The following is a description of a gene set: studied in species Homo sapiens from publication Chen Y, Wang X (PMID 31504780) Human Gene Set: MIR4729 Genes predicted to be targets of miRBase v22 microRNA hsa-miR-4729 in miRDB v6.0 with MirTarget v4 prediction scores > 80 (high confidence targets)., and this is the list of marker genes: PDCD6IP, OGFRL1, CEP350, CHFR, STARD13, TBC1D12, CBFA2T2, DCAF10, ADAMTS5, CALHM5, ZBTB43, RFX3 (regulatory factor X3), CCNYL1, PLAC8, DNAJC9, KLF5, EIF1AY, ADD3 (NCBI Gene Id 121), DDT, MARCKSL1, EEA1, RORA, PLCXD3, NCAPD2, GRAMD2A (GRAM domain containing 2A), CHP1, GRM8, PAXIP1, HTR7, NECTIN1, GINS3, AGTPBP1, SREK1IP1, ACVR2A, DGKH, FGFR1OP2, TBCA (tubulin folding cofactor A), KLHL1, NT5M, CEP76, FUT2, IRS1, STEAP2, ZC4H2, SLC9A2, PAIP1, KIF21A, FGA, RBFOX1, PRR12, RARS2, INIP, SEC14L1, SGIP1 (SH3GL interacting endocytic adaptor 1), STX11, BRWD3, IL22, GABRA1, POU2F1, UBE2N, EXOC5, ITGA4, ACIN1, CDH9, HTR2C, SANBR, C5orf15, PDLIM5, JAZF1, TLR3, PTP4A1, PTPMT1, OLFM4, MDM2, CREBZF, TBX5, ALKAL2, UBE2QL1 (NCBI Gene Id 134111), RIN2, TMED10, CELF4, ATP8A1, LPGAT1, SEPTIN9, ITFG1, B4GALT1, MYRF, POMGNT2, MTRF1, HIPK1, GNG10, SH3GL3, ZMYND11, DDX60L, KIAA1958, DYNLT5, NUS1, MID2, ARHGAP25, MYEF2, SENP6, NEK7 (NCBI Gene Id 148565), CPPED1, MLPH, MBD2 (NCBI Gene Id 8932), KCTD9, LRFN5, ETNK1, DZIP1, GAD2, GPR180, MTMR6, OVOL2, WASF1, ZC3H6, DDX5, ZDHHC21, ATP6V0A2, PTH, GXYLT1, PPP6R2, TIE1, RFC1, CEP97, SLC10A2, RNF19A, ZFAND5, ZNF710, TRABD2A, SEMA4D, GPATCH2L, HACD1, SNAP25, PRPF38B, SLC35E1, RAB36, HCFC2, SLC6A4, AGL, ZNF528, ZNF559-ZNF177, AWAT1, UBE2G1, HCN1 (hyperpolarization activated cyclic nucleotide gated potassium channel 1), TAOK1, STOML1, FSD1L, FRAT1, FBXO22, KRT72, SCD5, IARS1, FRMPD4, RNF44, HOOK3, LRRC56, MEMO1, PDLIM1, ING1, CCDC9B, MTOR, ITGA6, UBA2, TGM3 (NCBI Gene Id 7053), GSPT1, SSTR1, RNF216, EFR3B, TNPO1, TPI1, BFSP2, NOP14, DCAF15, PCMTD2 (NCBI Gene Id 55251), TP53AIP1, LY6D, OTP, MAPK8, PGGT1B, NEXMIF, FGFR2, TRIM55, ARGLU1, TCP11L2, SPACA4, HMGCS1, ALX1, LIN54, AMOTL1, SLC35E3, SLC30A4, DCUN1D5, KLHDC8A, NUP43, FRAS1, RAB23, CCDC102A, SPIRE1, AEBP2, PUS7L, RIC8B, SOCS6, CACNB4, RNF103-CHMP3, SCPEP1, MITF, PREP, CGGBP1, EOMES, KIAA0825, SLC66A1LP, TLCD4, GLT6D1, AQP6, KDM7A, SKI, SIPA1L2, ZBTB1, PJA2, ZSCAN16, MAPK8IP3, SHC4, HOXA10, KLHDC2, PDGFRL, C2CD6, MTMR1, FFAR3, KIF2A, IL1B, TENM1, FOXO1, CCNT1, C16orf95 (NCBI Gene Id 100508034), ANKRD13C, CD300C, DCP2, WDR26, CCDC82, TMEM47, ARMC2, FUT9, CCDC59, ALDH7A1, IKZF1, CDY1B, PPIP5K2, FGF2, KCNN4, KLK12, SNAP23, ZNF177, PCNP, FAM13A, GDAP2, TNS3, GPC6, KCNMA1, NUFIP2, ABCG2, CAPN14, MOB1B, VWC2, DDX28, AQP4, MAPKAP1, ALG6, GUCY1B1, LRP8, COX18, IGFL1, KCNQ3, DDN, PKLR, SDCCAG8, RNF39, NOTCH2, AFF3, STRIP2, COX4I1, SLC6A1, SNX13, SOX9, ABCE1, MBTPS2, DPEP2, ZNRF2, ERCC6, TOLLIP, CHURC1, TDRD5, LRP6, UBR2, BRME1, PIP4P2, TUSC3, INO80D, ANAPC5, ZBTB49, KLHL9, AMD1, ERBB4, ADAMTS7, RHOJ, MMGT1, VSNL1, TRUB1, SEC22A, SLC22A15 (solute carrier family 22 member 15), TMEM45A, SAFB2, DEPDC1, FOXO4, KCNS2, MED8, MET, IPO5, TMEM62, MYADM, HIRA, KCNH8, ARL5A, EIF3A, UHRF1, ARL13B (ADP ribosylation factor like GTPase 13B), TPK1, PHB1, DOK6, ZNF304, CHCHD7, ANKRA2, SMIM14, ABCC12, ZNF655, RRAGC, LDLRAP1, PRKAA1, ZMYM2, BOC, IGSF11, SLIT2, SNTB1, DLL1, BBX, ZNF175, PITPNC1, RBL1, SPAST, CACNA2D1, NRXN3, NABP2, GABPA, CHRNA5, BMAL1 (NCBI Gene Id 406), RPL32, LRP2, HOOK1 (NCBI Gene Id 51361), CER1, TMEM38B, CREB3L2, UBE2C, SLC27A3, ZFX, F13B, P3H1, CYLD, ANKRD34C, CDY1 (chromodomain Y-linked 1), ZIC4, ANKRD34A, AS3MT, WNK1, KIAA0408, UBR5, FBXO36, ARFGEF3, UBASH3B, UQCRB, AK5, IDH1, NEK6, TMEM198, PRR23E, ZNF782, RPRD1B, RAD23B, ZNF519, MAT2B, EIF2A, DMGDH, ZNF704, EVA1C, MTCL3, CAV2, PTBP2, HOXD9 (homeobox D9), ERLIN1, RSPO3, SORBS1, MOB3B, ATP2B1, ADCYAP1R1, CNTN1, KLHL5, SP8, BDNF (NCBI Gene Id 627), FCGR1A, ZFP37, TNS1, QKI, ARL15, TP63, EXPH5, TCTN2, FAM135A, MS4A7, KITLG, GPBP1, CDC73, TRAPPC2, MIS18A, PDGFRA, PTGER3, CYB561, GOLGA6C, SLC26A7, HIPK3, RNF180 (ring finger protein 180), CCDC22, MARCHF7, MRPL14, CYP7B1, AASS, BATF, ZNF227 (NCBI Gene Id 7770), EDEM1, ZKSCAN8, SLC7A11, NAPEPLD, NUP98, TP53BP1, NEGR1, RXYLT1, GREM2, ANKRD46, CDV3, RTF1, IGSF10, ABL2, CRISPLD1, BPNT2, FAM241A, FOXA1, DHX58, TMEM170B, USP44, LARGE1, KCTD21, SOCS4, CA10 (carbonic anhydrase 10), SLC25A26, ARHGAP42, DUSP10, VCAN, DYNC1I1, FGF1, SLC1A2, DOCK3, MDFIC, RAB27B, ZNF638, COPB1, SPATA12, SMAD7, MBNL3, ANKRD1, SMARCA5, BRPF3, CEP128, BZW2, CD1B, MYRIP, PYGO1, SCYL3, RPL22L1, ENPP6, AKTIP, MED13L, KAT2B, TPP2, GLIPR1L2, MPC1, MCM9, EHHADH, MEOX2, STX12, PLEKHH2, UBE2D1, UBE2D3, MSMO1, LMAN2, RAI2, ANKS1A, CHST14, CCDC83, MCM4 (NCBI Gene Id 780917), SLC16A14, SATB1 (SATB homeobox 1), SPINK8, EYS, TTC19, TMEM241, ZNF385C, USP10, IAH1, YEATS4, RNFT1, PRRC1, PI4K2B, PARP11, BIRC6, BTBD10, ABCC4, AICDA, LRRIQ4, ZNF607, USP14, NCOA6, B4GALT7, SLC35G1, LAP3, SOCS5, TMEM131, ITPR1, TCHH, DGAT2 (diacylglycerol O-acyltransferase 2), ETV4, USPL1, SLC6A15, IRF2, IQGAP2, ILRUN, MYCBP2, MAP6 (microtubule associated protein 6), MAMDC2, UBE4A, RRH, PHACTR3, TONSL, SPAG9, OGN, GBF1, UNC13C, KCNA4, SFMBT2, TAC4, LINC01517, MRPS28, VIT, MAB21L1, PLCXD1, JPT2, PIAS2, NOVA1, VSTM2A, GARIN1A, INPP4A, THUMPD1, APRG1, PAFAH1B2, FAM76B, SLC25A16, OGT, UBP1, TMEM132B, SNTG1, TIGD2, STK38L, WDR31, PTGFR, HELLS, MED17, RAB3IP, UBIAD1, FBXO9, FZD8, CHAD, HOXC9, C9orf85, NRIP1, GCSAM, UBN2, DSC3, PLAC8L1, KIRREL1, ZCCHC10, RC3H1, TTLL7, ERLIN2, PRP4K, NCF1, EPHA5, FCGR1BP, MSL2, ZNF552, HYCC2, HUWE1, YWHAH (NCBI Gene Id 7533), DBT, NTAQ1, SPPL3, ZNF333, PKD1L2, HNRNPH3, FREM1, SCN11A, DCUN1D1, IPO7, TIMM17A, ANKRD28, EMSY, STAM (NCBI Gene Id 8027, signal transducing adaptor molecule), CTBS, GABRB2, KRBOX4, PDS5A, FAT3, SDHA, ING3, USP25, TRAK1, JMY, HDHD5, ZYG11B, TRAK2, MYO6, OSBPL6, RTN1, SLC10A7 (solute carrier family 10 member 7), RWDD3, SNAP29, DEFB106A, IRX3, KIF20B, ZMYM4, WDHD1, CCDC107, MBNL2, YTHDC2, LZTR1, CDC42SE2, CNOT6, AK9, SPTAN1, SLC1A1, HELQ, IL7, BICD2, VAV3, PKP4, FER (NCBI Gene Id 2241), PRDM1, FCHO2, HSCB, VPS13C, METTL2A, PHF6, ELAVL1, UBE2K, IRF6, INSM2, DSC2, ARL8A, NPAS3, MAGOH, OGA, ATP11C (NCBI Gene Id 57206), SYCP2, BCL11A, RNF38, RB1CC1, ERO1B, CADM2, TNFRSF11B, UBE2Z, RMND5A, DLGAP1, NFKB1, BRI3, EMC6, TREML4, DNAJC25-GNG10, ST18, ATXN1, FUBP1, VEZF1, BAIAP2L1, PTEN, MAP3K2, OSBPL11, MORC3, PRKAA2, CHMP3, SERINC1, CD55, AHCTF1, PRICKLE1, MARCHF6, RTKN2, TEAD1, SNX4, CRLF1, DNAJB14, GPR84, F2R, CEP41